The following is a description of a gene set: species: Mus musculus Mouse Gene Set: GOBP_PYRIMIDINE_DIMER_REPAIR The repair of UV-induced T-T, C-T and C-C dimers., and this is the list of marker genes: Sirt1, Ercc1, Ddb2, Xpc, Hmgn1, Polb, Ercc6, Polh